The following is a description of a gene set: Human Gene Set: GOCC_U4_SNRNP species: Homo sapiens A ribonucleoprotein complex that contains small nuclear RNA U4, a heptameric ring of Sm proteins, as well as several proteins that are unique to the U4 snRNP, most of which remain associated with the U4 snRNA both while the U4 snRNP is free or assembled into the U4/U6 snRNP or into a series of spliceosomal complexes., and this is the list of marker genes: SNRPN, DDX39B, SNRPD3, RNU4-2, RNU4-1, PRPF31, SNRPE (small nuclear ribonucleoprotein polypeptide E), SNRPG, SNRPGP15, SNRPD2, SNRPB, SNRPD1, SNRPF